The following is a description of a gene set: from publication Hervas-Stubbs S, Riezu-Boj JI, Gonzalez I, Mancheño U, Dubrot J, Azpilicueta A, Gabari I, Palazon A, Aranguren A, Ruiz J, Prieto J, Larrea E, Melero I (PMID 21108462) Human Gene Set: GSE17301_ACD3_ACD28_VS_ACD3_ACD28_AND_IFNA5_STIM_CD8_TCELL_UP species: Homo sapiens IFN alpha mediated gene expression pattern. The effect of IFN alpha on human CD8 T cells responding to antigen (signal 1) and costimulatory signals (signal 2) provided by beads coated with anti-CD3 and anti-CD28 mAbs. This analysis examined the effects of IFN alpha on human CD8 T cells responding to antigen (signal 1) and costimulatory signals (signal 2) provided by beads coated with anti-CD3 and anti-CD28 mAbs. Magnetically sorted untouched CD8+CD45R0- T cells from three different donors were unstimulated or stimulated with IFNa2b or with anti-CD3/CD28 Beads alone or along with IFNa2b or IFNa5 for 48 hours. Individual mRNA samples were analyzed using HG-U133A 2.0 array gene chips. Genes up-regulated in CD8 T cells activated by anti-CD3 and anti-CD28 versus those stimulated by IFNA5., and this is the list of marker genes: NEIL1, SLC29A1, MELK, RECQL4, AAAS, CCNB2, RUSC1, SLC1A4, VIPR2 (vasoactive intestinal peptide receptor 2, NCBI Gene Id 94613), ABHD17B, NID2, PLEKHA5, CFL1, TRIP13, ARID3A, RORC, CD99, DEFA6, NDST3, CDC42BPB, TSPAN4, CDKN2C, RAB32, CENPM, ACSBG1, RAD54L, ETV6, DRC3, H2BC14, ORC6, SH3GL3, SETBP1, SERHL2, TRAIP, LRRC20, ESPL1, DDX11, ASF1B, MXD3, FADS2, ZEB2, PKMYT1, PCBP3, GTF2H2B, HMHB1, LIMK2, HMGN2, MAGOH2P, SLC1A5, ATP2A1, HAUS5, GSS, SQLE, CBFA2T3, MUC16, SLC25A10, AHI1, SLC11A2, CTNNAL1, KANSL3, SREBF2, CD1B, CEP85, PSTPIP2, FXYD2, PLA2G2E, RTL10, AKAP3, PTPA, CC2D1A, SEPTIN8, GPR22, CHRNA3, TPX2, PLXND1 (NCBI Gene Id 23652), CEP97, HADH, TK1 (thymidine kinase 1), PCLAF, ATAD5, RNF141, KPTN, HSD17B6, HMGB2, DBF4B, PLAUR, CD1E, AP1B1, LCT, H4C3, EXO1, MZB1, LMAN1, LMF2, STK32B, TUBA1B, CD93, SFTPA2, KIFC1, GUCY1A1 (NCBI Gene Id 2982), NMU, GUCY1B1, INSR, HMGB3P1, HJURP, SORD, OSBPL1A, DAPK1, SPPL2B, RHOT2, TYMS, BEGAIN, XYLB, ITGA7, FANCA, SAGE1, ZNF208, GNA15, MRPL28, PC, HMGB1, GAS7, MAST2, LST1, PLPP3, GTSE1, DOHH, SAPCD1, SPAG4, PTGES2, PRRC2A, CDK1, CD1C, RRM2, FOXM1, CIAO3, NUSAP1, RAC3, ASPM, CIT, AEBP1, WDR62, ZW10, IQCC, ESRP2 (epithelial splicing regulatory protein 2), GALR1, DNTT, APOLD1, MBNL3, CDK6, GBF1, CDC25A, MAP3K20, DND1, CD4, HYI, LRCH1, PTCRA, POLQ, NRGN, QSER1 (NCBI Gene Id 79832), H4C1, DNMT3B, CLIC4, CIC, PTGDR2, DLGAP5, SCARF1 (NCBI Gene Id 8578), MICAL3, CDCA3 (cell division cycle associated 3), LRP1B, NCAPH2 (NCBI Gene Id 96652), HOXA10, SNAPC4, CACNB3, HLA-DRB4, HSPBP1, MAP1A (NCBI Gene Id 4132), ADISSP, MKI67, GART, CHML, GFI1, MYBL2, DEPDC1, PPME1, IRX5, DCLRE1B, CLSPN, CCNF, TERT, TOMM40, RAG1, SPACA9, CCHCR1, TROAP, FASTK, KIF2C